Given this list of marker genes DUT, MED1, MDM2, PRMT2 (protein arginine methyltransferase 2), HMGA1, TACC1, ASXL2, ASXL3, NR0B2, ASXL1, here is a description of the gene set: species: Homo sapiens Binding to a peroxisome proliferator activated receptor, alpha, beta or gamma. Human Gene Set: GOMF_PEROXISOME_PROLIFERATOR_ACTIVATED_RECEPTOR_BINDING